Given this list of marker genes Ggt7, Psmb5, Ggt5, Asrgl1, Psmb7, Ggt1, Psmb8, Tasp1 (taspase, threonine aspartase 1), Psmb9, Prss50, Psmb11, Psmb10, Psmb6, Ggt6, here is a description of the gene set: studied in species Mus musculus Mouse Gene Set: GOMF_THREONINE_TYPE_PEPTIDASE_ACTIVITY Catalysis of the hydrolysis of peptide bonds in a polypeptide chain by a mechanism in which the hydroxyl group of a threonine residue at the active center acts as a nucleophile.